Given this list of marker genes POU3F3, PAX2, JAG1, UMOD, TFAP2B, NOTCH1, WNK4, PKD1, CALB1 (calbindin 1), PAX8, KLHL3, PKD2, here is a description of the gene set: species: Homo sapiens Human Gene Set: GOBP_DISTAL_TUBULE_DEVELOPMENT The process whose specific outcome is the progression of the distal tubule over time, from its formation to the mature structure. In mammals, the distal tubule is a nephron tubule that begins at the macula densa and extends to the connecting tubule.